The following is a description of a gene set: The p53 tumour suppressor functions as a transcriptional activator, and several p53-inducible genes that play a critical proapoptotic role have been described. Moreover, p53 regulates the expression of various proteins participating in autoregulatory feedback loops, including proteins that negatively control p53 stability (Mdm2 and Pirh2) or modulate stress-induced phosphorylation of p53 on Ser-46 (p53DINP1 or Wip1), a key event for p53-induced apoptosis. Here, we describe a new systematic analysis of p53 targets using oligonucleotide chips, and report the identification of dapk1 as a novel p53 target. We demonstrate that dapk1 mRNA levels increase in a p53-dependent manner in various cellular settings. Both human and mouse dapk1 genomic loci contain DNA sequences that bind p53 in vitro and in vivo. Since dapk1 encodes a serine/threonine kinase previously shown to suppress oncogene-induced transformation by activating a p19ARF/p53-dependent apoptotic checkpoint, our results suggest that Dapk1 participates in a new positive feedback loop controlling p53 activation and apoptosis. Human Gene Set: MARTORIATI_MDM4_TARGETS_FETAL_LIVER_UP Genes up-regulated in non-apoptotic tissues (fetal liver) after MDM4 knockout. species: Mus musculus from publication Martoriati A, Doumont G, Alcalay M, Bellefroid E, Pelicci PG, Marine JC (PMID 15608685), and this is the list of marker genes: SNORD49A, HOXB9, ERO1A, EXOC4 (NCBI Gene Id 60412), ZBTB16, PHLDA3 (NCBI Gene Id 23612), HOXD1, SRRM2, PDK1, CPT1C, PPP1R3C, WIPI1, HK2, KMT2E, SLC6A14, AK1, CCNG1, PMAIP1, GALK1, LRRC32, ATP5F1E, PRTG, NAMPT, SESN2, PTPN14, ZIC2, DDIAS (NCBI Gene Id 84145), PLOD2, BNIP3L (BCL2 interacting protein 3 like), CD81, ATP5MK, PDE2A, HPRT1, DDIT4, STC2, VLDLR, SNRPG, A2M, KCNE3, SLC19A2, SPAG17, SYNM, UBE2K, TRIM6, SP6, ZNF688, PSRC1, LAGE3, COX6B2, NPM3, RPS18, DAPK1, PITPNM2, PTK7, ANO3, BNIP3 (NCBI Gene Id 664), ARRDC3, SUSD6, BTG2, KIFC1, KANK3, PFKL, RNF169, RB1, ARK2C, AK4, TMEM256, RALY, COA8, NME2, FAM181B, NDRG1, JAG2, TAGLN, KRT19, RAB5C, LMNB1, ABHD4, PIDD1, IGF2BP1, EGLN3, PRRC2C, GINS1, LRRFIP1, FAM114A2, UPP1, CLCN3, GRIP1 (NCBI Gene Id 23426), ANKRD37, CENPW, WDR54 (WD repeat domain 54), NAA20, CGREF1, NRN1 (NCBI Gene Id 51299), CDKN1A, PGK1, IFITM3, SIVA1, EIF4EBP1, PDXP, MTG1, APAF1, SEC61G, GLRX3, KDM5D, ADM, NDUFB9, MAPKAPK3, MAP3K20, BHLHE41, CAV1, PRELID2, CA12, CCP110, BTG3, WNT6, WDR36, SUSD4, MT1X, COX7A2, ENO1, TMEM143, RPL34, ASCL2, DPM3, ZMAT3, ST14, TMEM45A, VWF, HIGD1A, BOLA2, EOLA1, GNB1, ENHO, RPRM, ELP6, NPPB, TP53INP1, MGARP, DEF6, FAM162A, PIK3IP1 (phosphoinositide-3-kinase interacting protein 1), LUC7L2, DDIT4L, LLPH, FBXW9, EGLN1, KDM7A, CHAC1, HBB, WTIP, CDC34, DDX3Y, PIGP, P4HA2, TMEM63B, MIX23, PGM1, MDM2, ETV4, PERP, TAGAP, IMMP1L, PALM2AKAP2, CCN2, NME4, SOSTDC1, EI24, N4BP1, PFKP, UQCC6, THEM6, RPS12 (NCBI Gene Id 6206), HSPBP1, SAP30, PIGF, ZNF708, LSM7, PDE4B, PLCD4, NSMCE1, TFAP4 (transcription factor AP-4), DYNLL2, PHLDA1 (NCBI Gene Id 22822), PLEKHA2, TAP1, PTP4A3 (protein tyrosine phosphatase 4A3), CIART, PTPRVP, ZNF365, USF1, NR6A1, SNORA50C, MAB21L3, PLTP, NDUFA7, SLC16A3, BLOC1S2, RNF19A, IER3 (NCBI Gene Id 91950), DLX3, MNAT1 (NCBI Gene Id 4331), RHBDF2, COMMD2, FAT1, PITPNC1, REV1, POM121, FABP7, SLC66A3, JDP2, AEN, GBE1, RAP2A, CPNE2, PPP1R3G, HILPDA, FSD1, P3H2, DCXR, EIF2S3 (NCBI Gene Id 8422), HOXD4, NUDT5, DYRK3, CCNC, SERPINE2, MFAP3, BHLHE40, FOXO3, ARAP2, GLUL, KBTBD11, P4HA1, EDA2R, RAP2B, MIR219A2, TIMM8B, CEP170B, DUS4L